The following is a description of a gene set: PPM1K is a mitochondrial protein phosphatase that removes the inhibitory phosphorylation from the E1 beta subunit of branched-chain ketoacid dehydrogenase (BCKDH) to restore BCKDH activity. <br>BCKDH is responsible for the oxidative decarboxylation of branched-chain amino acid (BCAA) derivatives of leucine, valine and isoleucine, providing acetyl CoA and succinyl CoA intermediates for the Krebs Cycle. Loss-of-function mutations in subunits of BCKDH cause accumulation of toxic BCAAs in the urine, neurological defects and are the cause of Maple Syrup Urine disease (MSUD). More recently, a frameshift mutation in PPM1K was identified as the probable cause of a mild variant of MSUD. This frameshift introduces a stop codon at residue 151, destabilizing the protein, and transfection of PPM1K-deficient fibroblast lines with WT PPM1K restores BCKDH activity.<br> Reactome Pathway: H139Hfs13* PPM1K causes a mild variant of  MSUD part of: Maple Syrup Urine Disease studied in species Homo sapiens, and this is the list of marker genes: DBT, BCKDHA, PPM1K, DLD, BCKDHB